Given this list of marker genes HIPK1, HMBOX1, HIPK2, CDKN1B, MIR222, here is a description of the gene set: miR-222 in exercise-induced cardiac growth studied in species Homo sapiens Human Gene Set: WP_MIR222_IN_EXERCISEINDUCED_CARDIAC_GROWTH